Given this list of marker genes PGD, PGLS, PRPS2, PGM2, RBKS, PRPS1L1, TKT, TALDO1, RPE, RPIA, RPEL1, G6PD, PRPS1, DERA, SHPK, here is a description of the gene set: The pentose phosphate pathway is responsible for the generation of a substantial fraction of the cytoplasmic NADPH required for biosynthetic reactions, and for the generation of ribose 5-phosphate for nucleotide synthesis. Although the pentose phosphate pathway and glycolysis are distinct, they involve three common intermediates, glucose 6-phosphate, glyceraldehyde 3-phosphate, and fructose 6-phosphate, so the two pathways are interconnected. The pentose phosphate pathway consists of eight reactions:1. Conversion glucose 6-phosphate to D-glucono-1,5-lactone 6-phosphate, with the formation of NADPH; 2. Conversion of D-glucono-1,5-lactone 6-phosphate to 6-phospho-D-gluconate; 3. Conversion of 6-phospho-D-gluconate to ribulose 5-phosphate, with the formation of NADPH; 4. Conversion of ribulose 5-phosphate to xylulose 5-phosphate; 5. Conversion of ribulose 5-phosphate to ribose 5-phosphate; 6. Rearrangement of ribose 5-phosphate and xylulose 5-phosphate to form sedoheptulose 7-phosphate and glyceraldehyde 3-phosphate; 7. Rearrangement of sedoheptulose 7-phosphate and glyceraldehyde 3-phosphate to form erythrose 4-phosphate and fructose 6-phosphate; and 8. Rearrangement of xylulose 5-phosphate and erythrose 4-phosphate to form glyceraldehyde 3-phosphate and fructose-6-phosphate.<P>The oxidative branch of the pentose phosphate pathway, reactions 1-3, generates NADPH and pentose 5-phosphate. The non-oxidative branch of the pathway, reactions 4-8, converts pentose 5-phosphate to other sugars.<P>The overall pathway can operate to generate only NADPH (glucose 6-phosphate is converted to pentose 5-phosphates, which are directed to the synthesis of fructose 6-phosphate and glyceraldehyde 3-phosphate, which in turn are converted back to glucose 6-phosphate). The reactions of the non-oxidative branch can operate to generate net amounts of ribose 5-phosphate with no production of NADPH. Net flux through this network of reactions appears to depend on the metabolic state of the cell and the nature of the biosynthetic reactions underway.<p>G6PD, the enzyme that catalyzes the first reaction of the pathway, is more extensively mutated in human populations than any other enzyme, pehaps because these mutant alleles confer malaria resistance. Mutations affecting other parts of the pathway are rare, though several have been described and studies of their effects have contributed to our understanding of the normal flux of metabolites through this network of reactions. species: Homo sapiens part of: Metabolism of carbohydrates and carbohydrate derivatives Reactome Pathway: Pentose phosphate pathway